The following is a description of a gene set: Human Gene Set: HE_LIM_SUN_FETAL_LUNG_C2_DC3_CELL DC3 from publication He P, Lim K, Sun D, Pett JP, Jeng Q, Polanski K, Dong Z, Bolt L, Richardson L, Mamanova L, Dabrowska M, Wilbrey-Clark A, Madissoon E, Tuong ZK, Dann E, Suo C, Goh I, Yoshida M, Nikolić MZ, Janes SM, He X, Barker RA, Teichmann SA, Marioni JC, Meyer KB, Rawlins EL (PMID 36493756) studied in species Homo sapiens, and this is the list of marker genes: CD2, MTMR11, RNASE2, S100A8, NRGN, UPK3A, CES1